The following is a description of a gene set: Any process that modulates the rate, frequency, or extent of arachidonic acid secretion, the controlled release of arachidonic acid from a cell or a tissue. Mouse Gene Set: GOBP_REGULATION_OF_ARACHIDONATE_SECRETION species: Mus musculus, and this is the list of marker genes: Atp5pf, Pla2r1, Hrh2, Hrh3, Pla2g10, Avpr1b (NCBI Gene Id 26361), Mif, Syk, Sstr4, Ntsr1, Pla2g6